The following is a description of a gene set: species: Homo sapiens Human Gene Set: GOBP_RESPONSE_TO_REDOX_STATE Any process that results in a change in state or activity of a cell or an organism (in terms of movement, secretion, enzyme production, gene expression, etc.) as a result of a stimulus indicating redox state. Redox state refers to the balance of oxidized versus reduced forms of electron donors and acceptors in an organelle, cell or organ; plastoquinone, glutathione (GSH/GSSG), and nicotinamide nucleotides (NAD+/NADH and NADP+/NADPH) are among the most important., and this is the list of marker genes: SELENOS, VASN, SMPD3, ARHGDIB, CLOCK, BMAL1, NPAS2, FKBP1B, ADH5, RYR2, SIRT2, RNF7, GLRX2, SLC7A11